Given this list of marker genes COMP, TNFRSF1A, FGFR3, MEFV, LMX1B, here is a description of the gene set: The ability of the knee to move past its normal range of motion, (knee hyperextension is greater than 10 degrees). species: Homo sapiens Knee joint hypermobility Human Gene Set: HP_KNEE_JOINT_HYPERMOBILITY